The following is a description of a gene set: Genes predicted to be targets of miRBase v22 microRNA mmu_miR_6896_5p in miRDB v6.0 with MirTarget v4 prediction scores > 80 (high confidence targets). from publication Chen Y, Wang X (PMID 31504780) Mouse Gene Set: MIR_6896_5P species: Mus musculus, and this is the list of marker genes: Foxf1, Nexmif (NCBI Gene Id 97590), Enah, Clec5a, Slc6a15, Ap4e1, Sppl2a, Tbx18, Atg7 (autophagy related 7), Fam124b, Spidr, Fam13a, Sla2, Usp46, Kdm7a, Slc39a8, Rufy2, Phf19, Top1, Tnpo2, Mreg, Rab3c, Rorb, Clstn2, Clvs2, Zfp1008, Mei4, Asb13, Zfp935, Tle1, Zfp386, Ube2b, Zfp458 (zinc finger protein 458), Aplp2, Actc1, Stimate, Btk, Glod5, Ccbe1, Rcc1, Zfp820, Ankrd7, Zfc3h1, Commd2, Scnm1, Atp11c, Eif2ak4, Tfip11, Lrrcc1, Mad2l1, Igfbp7, Crebl2, Eif4a2, Lyrm4, Dpysl4, Myct1, Elmod2, Tmem154, Mthfd2l, Nhlh1, Zfp39, Tbc1d20, Rbx1, Plxdc2, Zcchc14, Abhd18, Frmd5, Rasal2, Hnrnpr, Emx2